The following is a description of a gene set: Any process that stops, prevents, or reduces the frequency, rate or extent of ferroptosis. studied in species Homo sapiens Human Gene Set: GOBP_NEGATIVE_REGULATION_OF_FERROPTOSIS, and this is the list of marker genes: SLC7A11, AIFM2, NFE2L2, NQO1, SQSTM1, SC5D, SLC25A1, HMOX1, ACLY, GPX4, FTH1, KAT2B, ADGRG1